The following is a description of a gene set: Focal adhesion Mouse Gene Set: WP_FOCAL_ADHESION studied in species Mus musculus, and this is the list of marker genes: Pip5k1c, Vwf, Col3a1, Flna, Itgb7, Map2k2, Col4a4, Ibsp, Pelo, Pten, Igf1, Lama5, Fyn (NCBI Gene Id 14360), Tln1, Itgb5, Map2k5, Lamb2, Egf, Col11a1, Lama1, Spp1, Rac1, Fn1, Actn1, Ppp1r12a, Col2a1, Col5a3, Gsk3b, Lama2, Tnr, Bcar1, Lamb3, Akt3, Ptk6, Egfr, Map2k6, Txk, Birc3, Mapk7, Ccnd3, Grb2, Lamc3 (NCBI Gene Id 99350), Lamc1, Rock1, Arhgap5, Vegfd, Akt2, Braf, Pxn, Farp2, Col5a2, Capn1, Bad, Ilk, Col5a1, Met, Rac2, Col4a1, Akt1, Pgf, Mapk6, Lama3, Rhoa, Vtn, Tnk1, Itgb8, Itgb6 (integrin beta 6), Itga11, Itga6, Itgb3, Zyx, Fgr, Col6a2, Pik3cd, Parvb, Actb, Itga2, Pik3r1, Thbs3, Vegfb, Pdgfrb, Crkl, Pdpk1, Cav1, Tnk2, Lamc2, Elk1, Shc3, Tnc, Crk, Itga9, Pak6, Itga5 (NCBI Gene Id 16402), Vegfa, Pdgfb, Mylk, Pik3r5, Itgam, Pik3ca, Chad (NCBI Gene Id 12643), Pdgfra, Pdgfd, Pik3r4, Ptk2, Ccnd2, Jun, Col4a2, Pak4, Rapgef1, Rock2, Mapk8, Tnxb, Col4a6 (NCBI Gene Id 94216), Lama4, Vav1, Vcl, Flt1, Rac3, Col1a2, Selenop, Tesk2, Mylk2, Pak2, Pdgfa, Itga7, Pak1, Mapk1, Thbs1 (NCBI Gene Id 21825), Birc2, Itgad, Map2k3 (NCBI Gene Id 26397), Blk, Mapk4, Pdgfc, Vasp, Itgb4, Bcl2, Itgae, Styk1, Actg1, Hgf, Shc1, Itgav, Src, Itga4, Mapk12, Araf, Cav3, Cav2, Raf1, Itga10, Myl6, Reln (NCBI Gene Id 19699), Col11a2, Itga3 (NCBI Gene Id 16400), Sos1, Lamb1, Erbb2, Vegfc, Hck, Pik3cg, Col1a1, Srms, Itgb2, Rap1b, Itgb1, Mapk9, Itga8, Ccnd1, Map2k1, Pik3r2, Thbs2, Pik3cb, Rap1a, Thbs4, Itgal, Itga2b, Rhob, Tnn, Itgax, Dock1, Pak5, Pak3 (p21 (RAC1) activated kinase 3), Diaph1, Cdc42